The following is a description of a gene set: studied in species Mus musculus Reactome Pathway: Synthesis of (16-20)-hydroxyeicosatetraenoic acids (HETE) This event has been computationally inferred from an event that has been demonstrated in another species.<p>The inference is based on the homology mapping from PANTHER. Briefly, reactions for which all involved PhysicalEntities (in input, output and catalyst) have a mapped orthologue/paralogue (for complexes at least 75% of components must have a mapping) are inferred to the other species. electronically inferred by orthology from the curated human pathway part of: Arachidonate metabolism, and this is the list of marker genes: Cyp1b1, Cyp4f15, Cyp2c66, Cyp4f18, Cyp2u1, Cyp4f40, Cyp2c65, Cyp1a1 (NCBI Gene Id 13076), Cyp1a2